Given this list of marker genes RAC1, DLX5, WNT5A, SLIT1, ERBB4, SALL1, SLIT3, ATF5, ROBO2, GSX2, SLIT2, ARX, UNCX, ROBO1, here is a description of the gene set: Human Gene Set: GOBP_OLFACTORY_BULB_INTERNEURON_DIFFERENTIATION The process in which a neuroblast acquires specialized features of an interneuron residing in the olfactory bulb. studied in species Homo sapiens